Given this list of marker genes KCNK2, KCNK16, KCNK4, KCNK7, KCNK5, KCNK9, KCNJ4, KCNK10, KCNK17, KCNK6, KCNK3, KCNK13, KCNK1, KCNK18, KCNK15, KCNJ2, KCNJ14, KCNK12, KCNJ12, here is a description of the gene set: Phase 4 describes the membrane potential when a cell is not being stimulated. The normal resting potential in the ventricular myocardium is between -85 to -95 mV. The membrane is most permeable to K+ and relatively impermeable to other ions therefore the K+ gradient across the cell membrane is the key determinant in the normal resting potential (Park & Fishman 2011, Grant 2009). In this phase, K+ currents are generated by inward rectifier potassium channels (KCNJs) and tandem pore domain K+ channels (KCNKs). Some Na+/K+-ATPases and Na+/Ca2+-exchangers can also play roles during this phase. part of: Cardiac conduction species: Homo sapiens Reactome Pathway: Phase 4 - resting membrane potential